Given this list of marker genes NF1, SRPX, PPP1CA, TGFB2, INHBA, CTNNA1, PPP2R1B, HTRA2, WWOX, RET, PPP2R1A, here is a description of the gene set: Any process that activates or increases the frequency, rate or extent of extrinsic apoptotic signaling pathway in absence of ligand. Human Gene Set: GOBP_POSITIVE_REGULATION_OF_EXTRINSIC_APOPTOTIC_SIGNALING_PATHWAY_IN_ABSENCE_OF_LIGAND studied in species Homo sapiens